Given this list of marker genes PPP1CB, HYKK, TTC23L, ERO1B, EYA4, CPEB4, KDM2A, KLF4, CD44, GOLGA8N, PHC3, B4GALT6 (NCBI Gene Id 9331), ARMC3, SLIT2, CDK12, CCND2, PRKG1, TRPA1, CYP51A1, GNG2, FGL2, ELF1, DPY19L2, ARHGAP6, NCKAP5, TMEM161B, NEK7, TPR, RC3H2, FAM107B, MOB1B, STK32A, PTPRM, ZNF175, INSC, KRT5, SEC62, PIK3CB, MYO1B, DMD, PARD6B, FUT9 (fucosyltransferase 9), CALCRL, CUL2, IRF6, TRPM6, PI15, DISC1, MAT2B, SLITRK4, GOLGA8T, SBF2, FAM117B, VAMP2, EIF4E3, ZC3H12C, UBALD2, PTAR1, KAT2B, ZNF211, FAM13B, NEDD1, INPP5B, GABRA5, BRF2, TBX18, ONECUT2, MERTK, EIF4A2, BEND2, ZC3H6, MLF1, KDM6A, CYP7B1, NETO1, TRIP13, KCNH5, GUCY1A2, SYN3, EEA1, RRP15, DDHD2, SMAD2, PDE9A, ABHD10, ANAPC10, RIPOR1, RAB11FIP3, ARL13B, ARHGAP20, ARHGEF6, PURA, PCDH7 (NCBI Gene Id 90855), CPEB3, BTF3L4, KL, SINHCAF, CEP104 (NCBI Gene Id 9731), LARP4, RASAL2, FYN, SPEN, RGMB, OR2L13 (olfactory receptor family 2 subfamily L member 13), NOL3, SH3BGRL2, ABCA5, ZNF260, IL7, DELE1, ADGRB3, NPIPB5, SCN8A, PTER, RBM41, SLC2A13, KALRN, RAI1, SMIM17, ATXN2, MICAL2, DGKH (diacylglycerol kinase eta), SH3RF1, JUNB, MYOT, RFX7, AAK1, LEMD3, TXLNB, SMIM14, ZNF681, PNISR, API5, RAB12, NBL1, EGR3 (early growth response 3), PREPL, PALS2, UTY, KRIT1, SEC63, CCDC88A, BDNF, DOCK10, DUSP1, MSR1, CYP8B1, RNF111, DNPEP, TENM1, CEACAM1, DACT1, TMTC1, BACH1, TMEM65, SPIRE2, AEBP2 (AE binding protein 2), CDKN2AIP, RAB11FIP2, ABL2 (NCBI Gene Id 27), POF1B, PPP2R5A, PPP1R9B, BTAF1, NT5C3A, STXBP4, TBC1D19, NPIPB11, ZFC3H1, GMPR, CXCL5, LRP1B (NCBI Gene Id 55424), GFPT1, MED12L, WDR43, TEAD2, DNAJC6, FYB2, AFG2A, NRXN1, DLG3, ARHGAP44, MMD, ZNF714, UVRAG, DHFR, WDR20, TMEM108, PALLD, NCALD, UBE2B, CYP26B1, MOSMO, RARRES1, MOSPD1, CREBRF, GRHL2, CDC42SE2, ZNF699, CAV2, TCP10L2, F9, YPEL2, AQR, ST6GALNAC3, TNFRSF11A, HNF4G (hepatocyte nuclear factor 4 gamma), MBL2, TTYH3, HOXA7, NR4A1, FRMD6, CADM2, NXF1, CDH11, TBX5, ODF2L, C7orf57, STRN, VPS29, OIP5, FZD3, BAG3, CDKL5, SPIN1, TMEM41B, FEM1C, RORA, PKHD1, DYNC2H1, IL20RA, CEP44, TSG101, KLF2, PMP22, C12orf75, TAS2R20, TEC, NEIL3, DDX4, CREB1, CAPRIN1, RGR, SERPINB1, KBTBD2, ZNF827, LINC03106, NUFIP2 (nuclear FMR1 interacting protein 2), GPC6 (NCBI Gene Id 10082), EREG, GOLGA8M, FRYL, SOCS4, LMOD1, NEGR1, NDUFA5, ARAP1, KIF13A, WIF1, CAMK4, DIPK2A, NHLRC2, FHIP2A, AKT1, ALG13, LPP, NXT2, ZFP36, SNAP25, CDC42EP4, TMEM184B, CAVIN2, NPR3, BMP3, ZDHHC21, BICD2, GIGYF2, IL1RAP, SSH1, CACNB2, RAP1A, NCAPG2, CNTN4, PYGO1 (NCBI Gene Id 283658), NAPB, FBXO8, C8orf34, FBXO34, CADM4, SLC16A7 (solute carrier family 16 member 7), ACSL6, LSAMP, KCNN3, SRCIN1, ARID2, MSX1, TMEM106B, PDPK1, SSH2, ZDHHC15, BPNT2, ST8SIA1, SCX, PLD5, MIPOL1, HIGD1A, TDRD7, ZNF85, SGTB, SLC35G2, FAM204A, GRHL1 (grainyhead like transcription factor 1), GOLGA8J, RRAS2, USPL1, ATXN7L1, SIK3, FRY, HOOK3, MANEA, NFAT5, ZNF703 (NCBI Gene Id 80139), RAB22A, SFT2D1, BACH2, PNPT1, DENND1B, ZFAND5, TAOK1, LRRC31, IGF2BP2, GOLGA8Q, WDR44, RAPGEF5, ARHGEF11, MKRN3, CEBPA, LCORL, STEAP2, FAM199X, OLFML2B, ANKRD18A, PTPRE (protein tyrosine phosphatase receptor type E), PRRC1, PTCH1, LRRC34, HS3ST3A1, SLMAP, ELAVL4, NAA15, SASS6, SLC2A4RG, HHIP, ZEB1, SVIP, EDNRB, MRPL57, IREB2, ZNF568, DLL4, BICDL1, C21orf91, RGCC, SAR1B, TIMP3, TNFAIP3, KYNU (kynureninase), FOXN3, TMEM178B, SACM1L, RFC5, ZBTB18, SP3, RAB30, ARFIP2, SATB2, IDS, TNS1, FAM241A, SUPT20H, UGT2B28, PTP4A2, ZNF275, ZNF280C, MATN3, MUC17, RIMKLB, GOLGA8H, ZZZ3, PALM2AKAP2, SKIL, SGPP1, RUFY2, CCDC169, OCIAD1, RNF217, ITGB8, SBDS, COBLL1, TMEM71, USP12, PTGS2, SGIP1, GAPVD1, here is a description of the gene set: Human Gene Set: MIR656_3P Genes predicted to be targets of miRBase v22 microRNA hsa-miR-656-3p in miRDB v6.0 with MirTarget v4 prediction scores > 80 (high confidence targets). species: Homo sapiens from publication Chen Y, Wang X (PMID 31504780)